Given this list of marker genes ADK, NUDT16 (NCBI Gene Id 131870), DGUOK, NUDT15, GUK1, ITPA, ADA, SAMHD1, RRM2B, here is a description of the gene set: studied in species Homo sapiens The chemical reactions and pathways involving a deoxyribonucleoside triphosphate, a compound consisting of a nucleobase linked to a deoxyribose sugar esterified with triphosphate on the sugar. Human Gene Set: GOBP_DEOXYRIBONUCLEOSIDE_TRIPHOSPHATE_METABOLIC_PROCESS